Given this list of marker genes GPR137, IL20RA, MIR34A, SLC4A2, TGFB1, S1PR1, MIR16-1, CD38, GPR137B, PRKCA, MIR199B, ROCK1, MIR20A, MIR195, GREM1 (NCBI Gene Id 7947), BGLAP, ARAP1, MIR214, MIR143, DDR2, TNFAIP3 (NCBI Gene Id 7128), TMBIM1, GPNMB, CALCA, CEACAM1, ITGB3, LEP, SPP1, IL15, MIR27B, INPP5D, MIR34B (NCBI Gene Id 407041), LTBP3, TP53, PLEKHM1, ROCK2, PPP3CA, THBS4, SYK, TMEM119, SRC, SFRP1, IL12B, MDK, AGER, MIR29B1, DCSTAMP, NF1, YPEL4, CST3, CSF1R, PPARG, SYT7, SIGLEC15, IL23A, FSHR, IL18, SUCO, TNFRSF11A, MIR34C, PDK4, DEF8, HAND2, HRG, MIR15B, RUFY4, RUNX1, LEPR, TNFSF11, P2RX7, CLDN18, IL21, CARTPT, FSHB, TMEM64, BCR, MIR17, MC4R (NCBI Gene Id 4160), UBASH3B, CSK, MIR199A1, ADAM8, IL6, FLT4, IL2, IAPP, here is a description of the gene set: studied in species Homo sapiens Human Gene Set: GOBP_REGULATION_OF_TISSUE_REMODELING Any process that modulates the frequency, rate, or extent of tissue remodeling.